The following is a description of a gene set: studied in species Mus musculus Human Gene Set: QI_HYPOXIA Genes up-regulated by hypoxia in TRAMP-C cells (prostatic cancer). from publication Qi J, Nakayama K, Cardiff RD, Borowsky AD, Kaul K, Williams R, Krajewski S, Mercola D, Carpenter PM, Bowtell D, Ronai ZA (PMID 20609350) Neuroendocrine (NE) phenotype, seen in >30% of prostate adenocarcinomas (PCa), and NE prostate tumors are implicated in aggressive prostate cancer. Formation of NE prostate tumors in the TRAMP mouse model was suppressed in mice lacking the ubiquitin ligase Siah2, which regulates HIF-1alpha availability. Cooperation between HIF-1alpha and FoxA2, a transcription factor expressed in NE tissue, promotes recruitment of p300 to transactivate select HIF-regulated genes, Hes6, Sox9, and Jmjd1a. These HIF-regulated genes are highly expressed in metastatic PCa and required for hypoxia-mediated NE phenotype, metastasis in PCa, and the formation of NE tumors. Tissue-specific expression of FoxA2 combined with Siah2-dependent HIF-1alpha availability enables a transcriptional program required for NE prostate tumor development and NE phenotype in PCa., and this is the list of marker genes: SOX9, GPI, SH3YL1, INSIG1, PLEKHA2, GRHPR, BNIP3, CDC42EP2, AMPD3 (adenosine monophosphate deaminase 3), EFNA1, AK4 (NCBI Gene Id 387851), ADM, SPG21, IL13RA1, CAPN5, DUSP1, NRN1, SQLE, RASL12, HK1, KCNB1, PPP1R3B, PDXP, ME2, BHLHE40, ITPK1, EGLN3, DYRK1B, HMGCL, SLC41A2, SERTAD1, CIART, IER3, CASP6, PFKP, GPR35, OSTF1, EGLN1, ADIPOR2, DDIT4, ACSS2, KIF21B, PDK1, PLOD1, HDAC5, PGM1, SLC2A1, FAM117B, BCL2L11, HOMER1, ARRDC3, CRYAB, VLDLR, CCNG2, JMJD6, LSS (lanosterol synthase), CDHR1, SLC19A2 (solute carrier family 19 member 2), HIGD1A, P4HA2, NDRG1, LOX, MVD, DIXDC1, ALDOC, KDM4B, VEGFA, SCD, NSDHL, PKP2 (plakophilin 2), VHL, RNF126, CYP51A1, CTNS, ESPN, CYP2S1, PLOD2, FOXO3, MAP3K1, CDKN1A, PCYT1B, HK2, FZD1, ABCB6, STC1, ATG9B, LPIN1, GLS2, COL12A1, PGAM1, MBOAT2, CA9, ACER2, TRIOBP, ELMO1, RNF19A, ACAT2, CD109, ITGA11, P4HA1, MPP2, GPR146, MXI1, FFAR4, RORA, HMOX1, KDELR3, PAFAH1B3, TNFSF9, GCH1, IRX2, KRT19, ACAP1, HES6, PFKL, GALR2, NDRG2, MT1X, KCNK2, TRERF1, HPSE, IGFBP3, SIAH2, PPP1R3C, ZBTB8B, SAP30, NAA80, REEP1, GTF2E2, ALDOA, WHAMM, PGF, GBE1